Given this list of marker genes Lrp5, Sost, Kremen1, Kremen2 (kringle containing transmembrane protein 2), Dkk4, Dkk1 (dickkopf WNT signaling pathway inhibitor 1), Dkk2, here is a description of the gene set: This event has been computationally inferred from an event that has been demonstrated in another species.<p>The inference is based on the homology mapping from PANTHER. Briefly, reactions for which all involved PhysicalEntities (in input, output and catalyst) have a mapped orthologue/paralogue (for complexes at least 75% of components must have a mapping) are inferred to the other species. Reactome Pathway: Negative regulation of TCF-dependent signaling by WNT ligand antagonists electronically inferred by orthology from the curated human pathway part of: TCF dependent signaling in response to WNT species: Mus musculus